The following is a description of a gene set: species: Homo sapiens Genes down-regulated in comparison of regulatory T cell (Treg) versus conventional T cells. Human Gene Set: GSE15659_TREG_VS_TCONV_DN from publication Miyara M, Yoshioka Y, Kitoh A, Shima T, Wing K, Niwa A, Parizot C, Taflin C, Heike T, Valeyre D, Mathian A, Nakahata T, Yamaguchi T, Nomura T, Ono M, Amoura Z, Gorochov G, Sakaguchi S (PMID 19464196) Gene expression profiles of subsets of CD4+ T cells according to their expression of FoxP3 and CD45RA were compared. FoxP3 is a key transcription factor for the development and function of natural CD4+ regulatory T cells (Tregs). Here we show that human FoxP3+CD4+ T cells are composed of three phenotypically and functionally distinct subpopulations: CD45RA+FoxP3low resting Tregs (rTregs) and CD45RA-FoxP3high activated Tregs (aTregs), both of which are suppressive in vitro, and cytokine-secreting CD45RA-FoxP3low non-suppressive T cells. The proportion of the three subpopulations characteristically altered in cord blood, aged individuals, and patients with immunological diseases. Terminally differentiated aTregs rapidly die while rTregs proliferate and convert into aTregs in vitro and in vivo as shown by the transfer of rTregs into NOD-scid-common gamma-chain-knockout mice and by TCR sequence-based T cell clonotype tracing in peripheral blood of normal individuals. Taken together, the dissection of FoxP3+ cells into subsets enables one to analyze Treg differentiation dynamics and interactions in normal and disease states, and to control immune responses through manipulating particular FoxP3+ subpopulations., and this is the list of marker genes: SNORA37, TINAG, ALG12, GALT, POLR2C, ACVRL1, TOMM5, TPH2, PASD1, UQCC2, PKD1L1, GOLGA6A, ZNF618, CD1A, DCUN1D1, LMTK3, PYGL, MMP16 (matrix metallopeptidase 16), ANKFY1, POU2AF2, PTPRM (NCBI Gene Id 5797), ZNF155, APOC1, NDUFB2-AS1, TMEM223, VPS45, BRD9, FAM204A, MMP27, CACNA2D1 (NCBI Gene Id 781), HESX1, TRPC5OS, IL27RA, MASP2, TCL6, NUMBL, ITGA8, ITGA4, PEG3, FBXL17, ME2, WIPF3, EFHC2, ALPP, FASTKD1, CNTN6, MOS, C1QTNF9, UROS, USP27X-DT, ARFGAP1, TDRD10, LINC00928, SIGLEC9, OLFML2B, PPP1R3F, QTRT2, GPR171, ASMTL-AS1, TTLL1, NR2F2, IGSF1, AK8, NLRP11, CSNK1G2, RNASE6, IGFBP7, ABHD6, AP3D1, THSD7B, ADAMTSL3, SLC12A2-DT, BHLHE40, FZD6, ALOX15, PIK3CB, ATP6AP1L, KCNJ16, LILRA2, NOXO1, P2RY14, NWD2, DUSP7, POU4F3, DMGDH, HINT1, CNIH3, ACVR2A, CRBN, ASH1L-AS1, NKTR, CD2AP, NHSL3, LLGL1, BOLA3, RHOBTB2, PLXNA3, KHDC3L, RIMS1, C15orf32, IGLV6-57, KATNAL2, IL11RA, LINC00879, HUWE1, ERGIC1, MRPL57, CATSPERB, C8orf48, PTCSC1, FRY, LINC00887, DNAJB8, CLIC6, PDE4D, SECTM1, WDR35, NECAB2, GAS6, CREB3L3, ITIH2, ADAM32, TGFBI, ANK3, P2RY13 (purinergic receptor P2Y13), FOXG1, TENM2, GBP4, RAB3IL1, GHR, BAALC-AS2, TC2N, TP53TG5, H2AC4, HGSNAT, GJA1, FAR1 (fatty acyl-CoA reductase 1), SMIM10L1, RIPK1, TSPYL5, GCM1, PRKY (protein kinase Y-linked (pseudogene)), PANK1, VPS13A, LINC00933, ABCC13, RPS6KA3, RFPL1S, ELOVL7, TMSB15B-AS1, ATP2B2, RPS29, ZFHX3, LPAR1, MUC13, HS3ST6, GGPS1, NMRK1, CCDC42, LINC00648, ZNF408, XPOT, PCDHGB5, SHFL, C8orf58, RCN1, DUSP13B, TMEM104, PPP1R14B, LINC00567, HIPK4, SENCR (NCBI Gene Id 100507392), RAB27B, LINC01020, IGSF9B, ISL1, SNX18, MYO3B, PTPRH, AMPD2, ALDH18A1, LINC00511, FBXW9, KLHL5, B3GALT5, C2orf88, PLEKHA7, PRSS33